Given this list of marker genes ATP6V1C2, NOS2, ATP6V1D, MPO, CYBA, ATP6V0A4 (NCBI Gene Id 536), ATP6V0E1, ATP6V1A, LPO, ATP6V0A1, ATP6V0E2, ATP6V0C, NCF2, NOS3, ATP6V1C1 (NCBI Gene Id 528), ATP6V0D1 (NCBI Gene Id 9114), ATP6V0B, ATP6V0A2 (NCBI Gene Id 7854), ATP6V0D2, ATP6V1G1, ATP6V1B1, ATP6V1E1, SLC11A1, ATP6V1G3, ATP6V1G2, TCIRG1, ATP6V1B2, NCF4, NCF1, RAC2, ATP6V1H, ATP6V1F, HVCN1, CYBB, NOS1, ATP6V1E2, here is a description of the gene set: species: Homo sapiens Human Gene Set: REACTOME_ROS_AND_RNS_PRODUCTION_IN_PHAGOCYTES ROS and RNS production in phagocytes